Given this list of marker genes NLGN2, SLC27A3, IRAG1, VIM, ADAMTS2, HRAS, PLPP3, ATP2A2 (NCBI Gene Id 488), FABP5, MYL9, TMEM204, DST, ACER2, TRPC1, QRICH2, MYLK, EXT1, CNP, PCBP4, SGCB, C1QTNF4 (C1q and TNF related 4), TGFBR3, GPR3, AMOTL1 (NCBI Gene Id 154810), SNAI2, NTRK2, PCDHGC3, PAMR1, VIT, CPXM1, LGR6, BACH1, GPR176, GPR87, MRGPRF, SYNM, CDH4, RBPMS, STAC, ANGPTL2, DPYSL3, LEP, LTBP4, BCAR1, DUSP7, CALML3, AEBP1, FAM216A, CD70, ITGB1, ASPHD2, GPSM1, TUBB6, EVC, EPAS1, TCF7L1, HACD1, LRRN1, C1QTNF12, TSPYL2, PXN, SERPINH1 (NCBI Gene Id 89588), HEG1, ADAMTS1, MATN2, MAOB, SLIT3, SMIM13, AKT3, ACTG2, INKA1, SULF1, RFLNB, TINAGL1, FEZ1, CHST3, TOX, RAPGEF1, PTPRT, SCARF2, EVA1A, VSIR, SEC24D, GNB4, KRT5, L3HYPDH, PDLIM7, DUSP6, SERPINF1, TES, LIMA1, CSRP2, WIPF1, TM7SF3, PTPRE, EDNRB, PDPN, PRRX1, PTGS2, PHLDB1, FGL2, RECK (reversion inducing cysteine rich protein with kazal motifs), RASL12, TAGLN, SEMA5A, CYGB, DZIP1L, IGFBP6, FJX1 (NCBI Gene Id 24147), TENM3, SLC6A8, TPST1, CCN2, TIMP3, GJC1, SIMC1, ARSI, CPNE8, DCBLD2, PODN, MTCL2, PLXNA2, IL17RD, PPP1R3C, IL6ST, LRCH2, ENPP2, CDH3, ELOVL4, NRP2, KLHL42, TGFB1I1, SLC25A4, EGFR, NXN, MYC, SHE, MEDAG, MMP2, DLL1, CALU, TSKU, EFNB1, SERPING1, TBX2, IGFBP2, COL18A1, ZC3H12B, FAM184A, VSNL1, RCSD1, ARHGEF28, ARHGEF25, CLIP3, MAP3K7CL, ERF, KLHL21, SCML2, FGFRL1, COL5A2, AOPEP, CXCL14, PDGFA, ADGRA2, FXYD1, PCOLCE, FBLN7, MTSS1, MCAM, SLIT2, TNS1, CD36, JAM3, KCNMB1, ABTB3, TRIM9, BVES, STXBP4, DMWD (DM1 locus, WD repeat containing), FAS (Fas cell surface death receptor), STAC2, ARHGAP24, THSD1, LRP4, CCDC85B, ITM2A, POU3F1, OSBPL6, EPDR1 (ependymin related 1), ADGRL1, PDLIM4, BCOR, SEMA3C, RARRES2, EBF3 (NCBI Gene Id 276717), GOLIM4, PLS3, PLA2G7, VCAN, NETO2, COL4A1, COL23A1, HDAC4, DIPK2A, OXTR, CSDC2, COL9A2, CALD1, DLK2, PKD1, GNG11, EGR2, CSPG4, FOXP1, EPHB1, LCAT, MGARP, CDH13, GNAI1, LAMB3, SCN4B, SPRED1, HGFAC, TIE1, KCNMA1, ARK2C (arkadia (RNF111) C-terminal like ring finger ubiquitin ligase 2C), STARD8, DOCK10, PARD6G, BMAL1, AXL, SCHIP1, SDK2, SH2D5, DCHS1, TWIST2, MEST, TMEM121, MYH11 (myosin heavy chain 11), EDARADD, TRIM29, FHL1, CRISPLD1, NT5E, FLNC, COL16A1, LBH, ARMH4, TNS4, TCOF1, MSX1, TMEM64, HSPG2, PLPP1, CNRIP1, ABI3BP, KCNIP3, HSPB2, NGF, TSHZ2, SLC1A5, FLRT2, POSTN, PPP1R14A, LMOD1, AQP9, BMP1, MFNG, GPC3, TMEM178A, PRX, JAG1, LARGE2, IL6, QKI, ID4, FMOD, TMEM255B, KRT16, ACTA2, PPP1R16B, DCUN1D3, MBNL1, GSN, UCN2, NDN, LAMB1, SKI, HS3ST3A1, IGFBP3, LCA5, ITGA9, CLXN, MEG3, WTIP, TTYH2, CNN1, KRT75, TCF4, BAG3, UPP1, GJA1, MPDZ, ECRG4, GYPC, SLC4A3, PALM2AKAP2, PRICKLE1, IL1B, EID3, NRCAM, MIA, RND3, NBL1, C19orf12, ELK3, PPP1R18, TRO, CDC42EP2, PRNP, COL4A2, RHOJ (NCBI Gene Id 57381), WIF1, SSH1, IL24, RUSC2, CADM1, RAB34, COL7A1, SMTN, ANKRD1, TMEM47, CLMP, SYDE1, NSG1, CCND2, SSBP2, LGALS7, ICAM1, SLC12A4, CRLF1, PLCH2, ZNF219, SLC1A3, ZNF423, ARHGAP25, ARHGAP20, PGF, AHI1, SLC27A6, LRRC8C, COL14A1, YAF2, SOBP, SNCA, LUZP1, PKNOX2, PSD2, CHST7, LRP1 (NCBI Gene Id 4035), OSR1, NRP1, ITGA1, TP63, RELN, P3H2 (prolyl 3-hydroxylase 2), SNTB2, MEF2C, SLCO3A1, BCL2L11, ELP5, LIFR, SRGN, FBXO30, ANTXR1, NECTIN3, FERMT2, AGPAT4, POGLUT2, SIAH2 (siah E3 ubiquitin protein ligase 2), NUDT11, SGIP1, MSRB3, LHFPL6, MXRA7 (NCBI Gene Id 54588), PROS1, SH3TC1, ARC, RASIP1, JAM2, IL17B, GEM, MICAL2, PPP2R2B, TACC1, APOE, MALT1, ENC1, P3H1, NNMT, ITGA6, PXDC1, PCDH18, CAVIN2, COL5A1, CCDC3, LAMC1, CARD10, UNC45A, CACNB4, BMP7, LAMA1, KRT14, BNC1, CBLB, SLC38A5, SLC2A3 (NCBI Gene Id 94827), PCDH19, SPHK1, PHLDA3, FHOD3, PRDM1, ISM1 (NCBI Gene Id 140862), COL17A1, IRX4, FZD8 (NCBI Gene Id 8325), SRPX, CAV1, TSHZ3, PKP1, MYOCD, HTRA1, TPM2, THBS1, ITGB4, POPDC2, DKK3, MAMDC2, MME, ACVR2A, PLEKHA4, TAMALIN, EGR3, RCN3, LAG3, NPTX2, TMEM201, THY1, LAMA3 (laminin subunit alpha 3), PRICKLE2, SBSPON, KANK4, SVEP1, EEPD1, COL12A1, ADARB1, ALDH1L2, LGALS1 (NCBI Gene Id 3956), CTNNAL1, CRYAB (crystallin alpha B), VGLL3, ETS1, NTF3, NGFR, RARB, FST, EOGT, HAS2, PCDH7, KLHL29, SORBS1, LIMS2, PEG3, SORCS1, RFX2, IGFBP4, NRG1, CDKN1A, SOX11, here is a description of the gene set: studied in species Mus musculus from publication Lim E, Wu D, Pal B, Bouras T, Asselin-Labat ML, Vaillant F, Yagita H, Lindeman GJ, Smyth GK, Visvader JE (PMID 20346151) INTRODUCTION: Molecular characterization of the normal epithelial cell types that reside in the mammary gland is an important step toward understanding pathways that regulate self-renewal, lineage commitment, and differentiation along the hierarchy. Here we determined the gene expression signatures of four distinct subpopulations isolated from the mouse mammary gland. The epithelial cell signatures were used to interrogate mouse models of mammary tumorigenesis and to compare with their normal human counterpart subsets to identify conserved genes and networks.METHODS: RNA was prepared from freshly sorted mouse mammary cell subpopulations (mammary stem cell (MaSC)-enriched, committed luminal progenitor, mature luminal and stromal cell) and used for gene expression profiling analysis on the Illumina platform. Gene signatures were derived and compared with those previously reported for the analogous normal human mammary cell subpopulations. The mouse and human epithelial subset signatures were then subjected to Ingenuity Pathway Analysis (IPA) to identify conserved pathways.RESULTS: The four mouse mammary cell subpopulations exhibited distinct gene signatures. Comparison of these signatures with the molecular profiles of different mouse models of mammary tumorigenesis revealed that tumors arising in MMTV-Wnt-1 and p53-/- mice were enriched for MaSC-subset genes, whereas the gene profiles of MMTV-Neu and MMTV-PyMT tumors were most concordant with the luminal progenitor cell signature. Comparison of the mouse mammary epithelial cell signatures with their human counterparts revealed substantial conservation of genes, whereas IPA highlighted a number of conserved pathways in the three epithelial subsets.CONCLUSIONS: The conservation of genes and pathways across species further validates the use of the mouse as a model to study mammary gland development and highlights pathways that are likely to govern cell-fate decisions and differentiation. It is noteworthy that many of the conserved genes in the MaSC population have been considered as epithelial-mesenchymal transition (EMT) signature genes. Therefore, the expression of these genes in tumor cells may reflect basal epithelial cell characteristics and not necessarily cells that have undergone an EMT. Comparative analyses of normal mouse epithelial subsets with murine tumor models have implicated distinct cell types in contributing to tumorigenesis in the different models. Human Gene Set: LIM_MAMMARY_STEM_CELL_UP Genes consistently up-regulated in mammary stem cells both in mouse and human species.